The following is a description of a gene set: studied in species Homo sapiens Genes predicted to be targets of miRBase v22 microRNA hsa-miR-1270 in miRDB v6.0 with MirTarget v4 prediction scores > 80 (high confidence targets). from publication Chen Y, Wang X (PMID 31504780) Human Gene Set: MIR1270, and this is the list of marker genes: BACE1, ASPH, BORCS7, EPPIN, POLI, APAF1, CAMK4, SET, N4BP2L1, ENTPD3, TCF20, IRF2BP2, CHSY1, CD276, PIK3CA, B9D1 (B9 domain containing 1, NCBI Gene Id 27077), COPS4, LYSMD1, LAMB4 (laminin subunit beta 4), STOML3, CEP164 (NCBI Gene Id 22897), SPTBN1, SH3BGRL2 (NCBI Gene Id 83699), POLR3C, OLA1, UBASH3B, ATXN7L1, ANKRD44, CBLIF, CIR1, XKR9 (NCBI Gene Id 389668), C1orf174, UNC5D, RFC5, HEXA, CD209, GTDC1, ZIC5, ZCCHC14, SENP5, TMEM242, EDIL3, AFP, DGKE (NCBI Gene Id 8526), POU2F3, HLA-DQA1, CNTN3, EPB41L4B, HNRNPU, SMCO4, ZDHHC15, SDC4, MAN1A1, PDE1C, GLI2, KLHDC3, MKX, NDUFAF5, CATSPERE, DNAAF3, TESC, HAS1, SLC24A2, TXNRD2, WBP2NL, IQCJ, CCNT2, PRSS37, ATP10D, SLC25A37, POLR1G (NCBI Gene Id 10849), KRTAP4-11, SGMS1 (sphingomyelin synthase 1), DCPS, C15orf40, GSPT1, UNC45B, PRR23C, SLITRK2